The following is a description of a gene set: Mouse Gene Set: MIR_7003_3P studied in species Mus musculus Genes predicted to be targets of miRBase v22 microRNA mmu_miR_7003_3p in miRDB v6.0 with MirTarget v4 prediction scores > 80 (high confidence targets). from publication Chen Y, Wang X (PMID 31504780), and this is the list of marker genes: Lmln, Tars1, Cfb, Mlst8, Cklf, Mrps2, Fezf1